Given this list of marker genes Elk1, Mettl13, Pyurf, Naa40, Lrp8, Ccdc178, Mmrn2, Tom1l2 (target of myb1-like 2 (chicken)), Zfp609, Carmil1, Raly, 2310022A10Rik, Prc1, Tor4a, Pla2g2f, Dmc1, Pecam1, Kcna5, Ubl4b, Tet3, Prkn, Nt5m, Hoxb9, Grb10, Cyp4a12b, Taok3, Ube3c, Mapk6, Cxxc4 (CXXC finger 4), Gria1, Clec14a, Sars1, Fam78b, D6Ertd527e, Nt5dc3, Gzmc, Tmem127, Pdxk, S1pr2, Luc7l3, Zmym3 (zinc finger, MYM-type 3), Mmp2 (matrix metallopeptidase 2), Acsm2, Tmem79, Car12, Jcad, Dnajc14, Elavl2, Srcin1, Mex3a (mex3 RNA binding family member A), Tfap2a, Cd79a, Fgfr1, Borcs8, Meox1 (mesenchyme homeobox 1), Mecp2, Pfkfb2, Zfp451, Seh1l, Wars1 (tryptophanyl-tRNA synthetase1), Pik3r2, Kcnc1, Slc25a42, Arhgef12, Fbxl17, Tnrc6a, Cd320, Ccl6, Wnt9b, Ufd1, Septin6, Pirt, Dppa1, Tmeff1, Mylk2, Siglecl2, Pou2f1, Tmem253, Crtc3, Ankrd24, Nexmif, Ctdsp1, Lta (lymphotoxin A), Alox12e, Csde1, Szrd1, Arhgef11, Npas2, Ist1, Atp2a1, Ybx2, Ube2d2a, Cyp4a12a, Cnot2, Kif1c, Map7d1, Ptp4a2, Celf3, Ccdc103, Gfra4, Pter, Bard1, Klc4, Naa25, Mtpap, Hoxa2, Srf, Klf17, Tm9sf3, Impdh1, Cul3 (cullin 3), Heph, Eef2k, Sorcs3, Cacnb1, Xpo7 (NCBI Gene Id 75101), Vwa1, Sytl4, Lnx2, Cacng5, Rtp3, P2ry4 (NCBI Gene Id 57385), Lgals8, Serf2, Aak1, Ilrun, Ddt, Smug1, Baz2a, St8sia3, Phf12, Cphx1, Hepacam, Ksr1, Tgfbr2, Kbtbd7, Plxnb1, Phactr1, Zbtb4, Susd1, Dcx, Gnao1, Samd4b, Selp, Lsm2, Clic5, Rab5a, Syndig1l, Dlg5, Crtc2, Mark2, Mid2, Sectm1a, Sh3pxd2a, Pi4kb, Paqr4, Gprc5b, Stk11ip, Sfxn1, Wac, Sbk3, Nptxr, Ctsc, Cnga1, Ms4a7 (NCBI Gene Id 77229), Frs2, Vamp2 (NCBI Gene Id 22318, vesicle-associated membrane protein 2), Tle5, Plagl1, Chd3, Kdelr1, Retn, Dut, Coro2b, Camk1g, Itga7, Fxyd2, Tmem164, Gorasp1, Dnaja2, Fam163b, Dhdds, Hoxd12, Cntnap2, Susd6, Tbc1d23, Parva, Yes1, Pxn, Itga10, Csnk1g1, Patl1, Smoc1, Diras2, Gpx5, Ino80d, Fkbp8, Pias1, Zbtb37, Mal, Hdac9, Kcnk3, Amfr, Scrt2, Cd93, Dennd11, Gng7, Manf, Lzts3, Pea15a, Pgap2, Bub1, H2ax, Slc22a8, Plpp7, Znrf1, Pum1, Atxn7l3, Slc4a8, Thra, here is a description of the gene set: Mouse Gene Set: MIR_7118_5P from publication Chen Y, Wang X (PMID 31504780) Genes predicted to be targets of miRBase v22 microRNA mmu_miR_7118_5p in miRDB v6.0 with MirTarget v4 prediction scores > 80 (high confidence targets). studied in species Mus musculus